The following is a description of a gene set: Human Gene Set: chr7p14 studied in species Homo sapiens, and this is the list of marker genes: MIR548N, KBTBD2, CICP22, TRGV1, RNU6-719P, TCP1P1, CPVL-AS1, ENSG00000286487, RP9, ENSG00000238906, RPS27P16, GGCT, CDCA3P1, INHBA, NPSR1-AS1, MATCAP2, SNX2P2, RN7SL132P, TARP, TRGJ1, POU6F2-AS1, HECW1-IT1, TRGV2, MIR550B2, RPL7P31, ADCYAP1R1, CDK13-DT, SNORA20B, TRGV3, CDK13, RN7SL496P, FKBP14-AS1, TRGVB, TRGVA, MIR550A2, TRGJ2, LINC00997, GARS1-DT, SCRN1, BBS9, GARS1, LINC01449, MARK2P13, LSM5, SEPTIN7P3, NCAPD2P1, RNU6-438P, TRGJP, AQP1, HERPUD2, TRGC2, CFAP144P1 (NCBI Gene Id 392661), RNA5SP229, LINC01448, SEPTIN7, RNU6-565P, RNU7-35P, HECW1, TRGV6, SSBP3P1, ENSG00000285412, YAE1, NOD1, MIR550B1, ENSG00000297045, PRR15-DT, TRGV10, ZNRF2P1, NEUROD6, TRGV5 (T cell receptor gamma variable 5), RWDD4P2, MINDY4, ZNRF2, BMPER, FKBP9, S100A11P2, POU6F2, GPR141, AOAH-IT1, ANLN, DPY19L2P3, CHN2-AS1, RNU6-575P, THUMPD3P1, CPVL-AS2, MTURN, AMPH, ENSG00000232930, ITPRID1, TRGV9, TRGC1, PSMA2, SUGCT-AS1, RPL7AP78, RALA, C7orf25, NPSR1, DPY19L2P1, STARD3NL, GLI3, TRGV7, GHRHR, CPVL, AOAH, RN7SL83P, EPDR1, POU6F2-AS2, SUGCT, RPS17P13, NPM1P18, TRGV8, AVL9, NECAP1P1, INMT-MINDY4, ELMO1, RNU6-388P, PLEKHA8, WIPF3, FKBP14, ENSG00000231418, TRGV4, ZNRF2P2, YAE1-DT, MIR1200, ENSG00000287893, PRR15, HMGN2P30, MIR3943, RPS29P14 (NCBI Gene Id 100129599), NT5C3A (5'-nucleotidase, cytosolic IIIA), PPP1R17, TBX20, TRPC6P10, TRGJP2, DPY19L1P2 (DPY19L1 pseudogene 2), ENSG00000261184, EEPD1, GTF3C6P3, ENSG00000286847, SFRP4, NANOGP4, CHN2, LINC01176, DPY19L1, LINC01450, KRT8P20, TMSB4XP3, RN7SL505P, MIR550A3, LINC00265, INMT, TMX1P1, RPS10P14 (ribosomal protein S10 pseudogene 14), TRGJP1, RP9P, TRIL, RNU6-1085P (NCBI Gene Id 106480043), MPLKIP, INHBA-AS1, MIR550A1, TRGV5P, PPP1R14BP4, PDE1C, LINC03013, MRPL32, ENSG00000236494, TRGV11, DPY19L1P1, ELMO1-AS1, CRHR2, SLC25A5P5, NME8, TRG-AS1, HERPUD2-AS1, VPS41 (VPS41 subunit of HOPS complex), GPR141BP, SEPTIN7-DT (SEPTIN7 divergent transcript)